The following is a description of a gene set: Expression profiling of Rag2-deficient Ets1++ and Rag2-deficient Ets1-- mature NK cells and WT bone marrow progenitors, WT T cells, and WT Pro B cells from publication Ramirez K, Chandler KJ, Spaulding C, Zandi S, Sigvardsson M, Graves BJ, Kee BL (PMID 22608498) studied in species Homo sapiens Human Gene Set: GSE37301_COMMON_LYMPHOID_PROGENITOR_VS_CD4_TCELL_DN Genes down-regulated in common lymphoid progenitors versus CD4 T cells., and this is the list of marker genes: ZDHHC17, BIRC5, NHLRC2, OCLN (occludin), TXNDC9, RNF8, TMX1, BLVRA, STYK1, ZNF137P, ANKRD36B, PHF20, NAA80, TRIB3, PCBP2, ZDHHC13, WIPI1, ZNF43, FBXO38, COPS6, PTPRU, PBX3, SLC29A2, NBR2, RTN3, ACOT7, GALC, MYOC, ILRUN, OARD1, TYMS, PTGDR, PIK3R4, RAD17, GMNN, PTPN2, CHAF1A, FLT3LG, HERC2, TSPYL1, FAM168B, MED14, ELMO1, ORC5, TST, IL10RA, KLHDC3, ATP5MJ, MANF (NCBI Gene Id 7873), JMJD1C, HADHB, ARPC5, RNASE6, KIF4A, TCEAL9, DHCR24, CDK13, ZMYM3, RIBC2, WDR41 (WD repeat domain 41), IFITM2, IL15, CHCHD3, GPAA1 (NCBI Gene Id 8733), F11R, GIMAP6, CLEC2B, TRPM2, PCNX1, TOPBP1, SLF2, SEPTIN6, NCOA6, P2RX7, F2R, SH3BGRL3 (SH3 domain binding glutamate rich protein like 3), ALOX5AP, ZNF217, ANKZF1, HPGD, TECR, SIDT1, DENND1B, DPYD, ZNF446, SMAD2 (SMAD family member 2), PROCR, CDK1, TARP, VPS26A, GNAI2, ARPP19, MXD4, ARPC3, NDUFAF1, PIKFYVE, PLSCR3, CSNK1G2, DENND4C, GGNBP2, PACSIN2, NOTCH2, UBR7, INPP5D, NFATC3 (NCBI Gene Id 82543), PSD4, CDT1, ZNF34, LYRM9, TBCA, C10orf88, PLEKHA1, ITPR2, SEC11A, SOCS2, PPT1, MYH9, RUBCN, GRAP, PPP2R5E, GSTP1, HMOX2, UBE2D2, FXR1, SKP2, IP6K1, TEX30, MYL12B, NMI, DNM2, CEP250, IQGAP2, MXD3, VBP1, STAT1, ZBTB38 (zinc finger and BTB domain containing 38), IDH1, MTX2, ATP5PD, LSM14B, YLPM1, SNX24, RWDD2B, SPTBN1, ITGA4, ZZEF1, P2RY10, KCNK13 (potassium two pore domain channel subfamily K member 13), HMGN3, LAMP2, VPS41, LGALS8, RAD51, NVL, MMP25, SOCS5, GDF11, DERL2, RNASEH2A, DYNC2H1, MYCBP, STAP1, ATP9B, GALNT10, VPS16, SLC2A10, TLE5, BNIP3L, PRDX2, SOS1, ATP2A3, DPF2, ERP29, MRPL40, CYB5R1, TRMU (tRNA mitochondrial 2-thiouridylase), BARD1, MDM1, INPP5A, CBR3, EXOC7, KIF21B, KIF14, TFDP2, UBE2L3, CYB5R3, STAU2, YTHDC2, SMIM8, ADCK2, HNRNPUL1, GRIK4, ZNF224, JAK1, RRM1 (ribonucleotide reductase catalytic subunit M1), STK39 (NCBI Gene Id 27347), MARK3, MSLN, EXOC3